Given this list of marker genes TTI2, CUL4A, BRCC3, RFWD3, BRCA1, MAP3K20, BRD4, PPP1R10, RAD51, BARD1, TELO2, CHEK2, ETAA1, BABAM2, RPA2 (NCBI Gene Id 6118), TTI1, BRCA2, FBXO4, RNASEH2B, WDR76, CCAR2, CRY1, FEM1B, here is a description of the gene set: Any process that modulates the frequency, rate or extent of a DNA damage checkpoint. Human Gene Set: GOBP_REGULATION_OF_DNA_DAMAGE_CHECKPOINT studied in species Homo sapiens